Given this list of marker genes Arfgap3 (ADP-ribosylation factor GTPase activating protein 3), Mtif2, Rasgrf1, Rapgef6, Rab24, Thtpa, Trip13, Kif5a, Rapgef3, Drg1, Smc6, Ddx47, Atad2, Sergef, Trpm2, Arl4d, Nudt6, Atp2c2, Fgd5, Kras, Spata13, Mfn1, Gem, Ighmbp2, Abcc6, Arhgap15, Septin1, Evi5l, Atp8b5, Ascc3, Tbc1d9b, Nvl, Adap1, Dhx58, Fitm2, Efl1, Gbp6, Obscn, Vav1, Hspa1a, Atp8b1, Prex1, Mcm4, Dcp1b, Gbp10, Abca12, Arhgap9, Grtp1 (GH regulated TBC protein 1), Psd3, Itsn1, Arhgef28, Arhgap35, Rabl2, Anxa7, Kifc5b, Abca6, Rhob, Iqsec3, Kifc2, Rnd2, Irgm2, Entpd3, Plcb1, Abcg8, Abca8b, Eif5, Arl6, Arl5c, Myo5a, Rragd (Ras-related GTP binding D), Zng1, Sh3bp5l, Ccdc88c, Arhgap12, Rgs7, Smarca4, Tuba1b, Psmc2, Tbcd, Abcb1a, Atp7b, Llgl1, Dennd5b, Ak6, Rasgef1b, Cyth4, Dhx15, Frmd7, Cant1, Phospho1, Rad51b, Nudt14, Nucb1, Gnas, Ola1, Rab9, Eif2s3y, Dennd1b, Psd2 (NCBI Gene Id 74002), Rheb, Dna2, Mcf2, Rhobtb1, Atp5f1a, Tap1, Gnb2, Arhgap23, Atp5po, Tbc1d10a, Rit2, Abca9, Atad2b, Ddx10, Arhgap5, Fignl2, Rhoa, Rcc2, Dqx1, Arhgef25, Arfgef3, Rap1gap, Gtpbp4, Arhgap33, Arhgap19, Elmod1, Dcp2, Rasa1, Rab26 (NCBI Gene Id 328778), Gdi1, Dhx30, Dab2ip, Thy1, Ift22, Tbc1d25, Rab10, Rhof, Atp11a (ATPase, class VI, type 11A), Rab39b, Tdrd9, Atp6v1a, Dock5, Enpp1, Arl2bp, Eif2s3x, Ric1, Rgs20, Mx2, Mcm3, Tbc1d14, Yme1l1, Htr2b, Agap1, Sgsm3, Rasa2, Afg3l1, Rab3b, Als2, Dock8, Abcc10, Abcd4, Ifih1, Macf1, Tubb4b, Irgc, Cyth3, Dock10, Rhot2 (ras homolog family member T2), Abcb6, Lsg1, Msh2, Arhgap6, Nudt11, Atp2b2, Iqsec1, Ralgapa1, Ralbp1, Arap2, Swsap1, Atp2a2, Abcc12, Prex2 (NCBI Gene Id 98394), Ralgps1, Mov10l1, Rab27a, Rgs17 (NCBI Gene Id 80505), Septin4, Rap1gap2, Abr, Rgs6, Dennd10, Atrx, Rab7, Rras2, Supv3l1, Myo9b, Arhgap22, Nudt16l1, Fitm1, Plekhg6, Atp2a3, Dock4, Ino80, Cct7, Gbp3, Arhgef15, Sbf1, Rgs5, Rasl10b, Arl5b, Gm5431, Rab33a, Dnah3 (dynein, axonemal, heavy chain 3), Mfn2, Gopc, Rasgrp2 (RAS, guanyl releasing protein 2), Evi5, Dhx57, Katna1, Iigp1, Nav1, Flcn, Plekhg1, Akap13, Kif17, Ocrl, Rnd3, Arfgef1, Tbc1d21, Rap1a, Nudt16, Rad50, Kif1c, Arhgef10, Rhobtb3, Tubb2b, Eif2b1, Atp1a4, Rgs11, Dock1, Dnm1l, Tiam1, Kif15, Rem2, Gnal, Rab4a, Gapvd1, Nubp1, Rab36, Atl3, Mtg2, Ddx19a, Tubb1, Ddx46, Myo1e, Fancm, Chd8, Sipa1l3, Ranbp2, Kif2b, Plpp6, Abcb10, Dgki, Dennd2a, Sipa1l1, Nlrp3, Helq, Tbc1d20, Psmc3, Iqgap1, Chd1l, Dmc1, Abcg3, Ruvbl1, Srcap, Ran, Eif2b2, Dcp1a, Rasgef1c, Myo3a (NCBI Gene Id 71549), Entpd2, Xrcc6, Kif5c, Arhgap8, Nudt5, Elmo1, Gna12, Rgl1, Kif7, Gm12185, Rab1a, Srp54c, Sh3bp5, Myo9a, Rhoj, Lonp1, Chn2, Atp13a5, Abcd3, Entpd7, Gng2, Arhgap29, Chd6, Tbc1d5, Rab7b, Dennd6b, Rgs1, Arhgap24, Diras1, Dnmbp, Sipa1l2, Cftr, Chtf18, D1Pas1, Ankrd27, Gnl1, Septin12, Ddx27, Arhgef10l, Ddx51, Blm, Rfc2, Rfc3, Eif4a1, Abcc2, Rasal3, Nudt17, Ralgds, Arf6, Ddx11, Arhgap20, Kif13b, Ythdc2, Abcd2, Fam13b, Kif1b, Fgd1, Atp5pb, Rab43, Psmc6, Psmc1, Adprm, Arf1, Rasgrf2, Acap1, Rin1, Abcc4, Ddx17, Atp6v1g3, Dennd2d, Morc2a, Tppp, Katnal1, Arhgap42, Mtss2, Gdpgp1, Gnao1, Gbp4, Gna11, Rab3gap1, Adap2, Tor4a, Kif2c, Mcm8, Plcd4, Kif13a, Rgs12, Spg7, Ralgapa2, Gm4841, Gnaq, Pms2, Arhgdia, Nudt9, Vav2, Igtp, Trap1, Fignl1 (NCBI Gene Id 60530), Plekhg5, Abce1, Rasef, Sh2d3c, Atp10d, Snrnp200 (NCBI Gene Id 9996), Rab38, Hspa8, Slfn8, Gripap1, Pelo, Gm1527, Als2cl, Tagap, Arf4, Ntpcr (nucleoside-triphosphatase, cancer-related), Arhgap25, Arl8a, Abca4, Rasgef1a, Afg3l2, Dock11, Aqr, Rab2a, Srgap2, Rapgef5, Arhgef1 (Rho guanine nucleotide exchange factor 1), Nuggc, Plce1, Hspa1l, Hltf, Kif12, Pgam5, Fhit (fragile histidine triad gene), Rfc1, Rab11a, Recql4, Iigp1c, Chm, Upf1, Gnat3 (G protein subunit alpha transducin 3), Arhgap31, Agap2, Abca1, Smc4, Rhot1, Rpgr, Septin10, Abcc3, Sgsm1, Eif5b, Srgap3, Rhov, Tsr1, Dennd2b, Agap3, Gnb1, Tcp1, Kif21b, Rerg, Ppa1, Abca13 (NCBI Gene Id 435246), Dnajc27, Ralgapb, Abcg1, Septin8, Kif2a, Vps4b, Eps8l1, Drg2, Sesn2, Nudt12, Rasa4, Arhgef7, Arhgef39, Rab32, Dennd4b, Eif4a3, Abcg4, Tubb2a, Gdi2, Rab17, Ddx49, Stard8, Arhgef18, Rabif, Dhx8 (DEAH-box helicase 8), Cracr2a, Hsp90b1, Cdc42ep2, Mcm6, Atp1a1, Psmc4, Hsp90aa1, Helz2, Ddx50, Myh3, Ddx28, Rhebl1, Entpd4, Atp2c1, Kif18a, Gnai2, Eftud2, Arhgef2, Sbf2, Gbp2b, Rin3, Arhgdib, Gpsm3, Kif14, Tsc2, Slit2, Rtel1, Abcf3, Ddx3y, Abcf1, Rasgrp4, Gch1, Rab22a, Rigi, Myh8, Gnat1, Tor1a, Lamtor2, Fgd6, Vps4a, Plpp5, Ddx1, Slc25a42, Kif21a, Morc3, Arfgef2, Fgd3, Dennd3, Tbc1d4, Chd5, Get3, Ddx20, Rab13, Tbc1d10b, Hspa1b, Wrnip1, Eps8l3, Abca5, Gmip, Arhgef38, Nudt18, Elmod2, Entpd6, Ngb, Prune1, Cct6a, Kif16b, Rasa3, Jun, Gtpbp2, Rap1gds1, Nkiras2, Kif26a, Nlrp1a, Dhx34, Stard13, Rabgap1l, Abcb11, Arhgap18, Ranbp10, Dnah2 (dynein, axonemal, heavy chain 2), Arhgap26, Rad51, Tubb3 (tubulin, beta 3 class III), Arf2, Gnai3, Rab30, Rcc1l, Rab8b, Gfm2, Pex6, Rab42, Abcb9, Gna15, Atp10b, Madd, Rad51d, Arhgef16, Tbc1d1, Arhgef6, Hfm1, Rp2, Sec61b (SEC61 translocon subunit beta), Mcm5, Kif3b, Tbc1d22a, Smchd1, Atp13a2, Nudt2, Arhgap21, Ercc6, Ccdc88a, Arl14, Gng4, Srp54a, Trim23, Gna13, Arhgap40, Nrp1, Rhog, Rinl, Nlrp1b, Aptx, Gbp2, Septin11, Tor3a, Actb, Arhgef17, Atp5f1c, Atp8b3, Psd4, Rgl2, Rab39, Smc1b, Tbcc, Chd9, Mlh1, Ric8a, Atad3a, Asap1, Acap3 (ArfGAP with coiled-coil, ankyrin repeat and PH domains 3), Ddx56, Morc4, Hspa5, Entpd1, Sec23a (NCBI Gene Id 217612), Rab6b, Rgs10, Cpeb2, Rab33b, Psmc5, Syde1, Entpd4b, Arhgap32 (Rho GTPase activating protein 32), Rabgef1 (RAB guanine nucleotide exchange factor (GEF) 1), Rgs14, Cdc6 (cell division cycle 6), G3bp1, Gpsm1, Ophn1, Bms1, Tiam2, Smpdl3a, Rap2a, Wdr41, Ercc2, Gbp7, Rasl12, Kif27, Cyth1, Gpsm2, Arhgap1, Pex1, Tbc1d15, Alpl, Deptor, Arhgef4, Rab9b, Rhoq, Kif3c, Arl11, Syde2, Ddx4, Nudt15, Sar1a (NCBI Gene Id 67913), Rhobtb2, Wrn, Cplane2, Abcb7, Iqgap2, Rapgefl1, Ifi47, Cct8, Arhgef12, Arhgap17, Twnk, Dock9, Rac3 (Rac family small GTPase 3), Tor1b, Lamtor1, Atp13a4, Rab3ip (RAB3A interacting protein), Atf7ip (NCBI Gene Id 76012), Hsp90ab1, Smarcad1, Srgap1, Abcg5, Mcm2, Abcd1, Chd4, Ddx3x, F830016B08Rik (RIKEN cDNA F830016B08 gene), Iqca1, Dennd5a, Arhgap27, Rit1, Arl15, Slfn9, Nudt3, Entpd8, Rab3a, Rngtt, Arhgef33 (Rho guanine nucleotide exchange factor 33), Sirpa, Ect2, Mycbp2, Kifc1, Rab18, Gnb4, Chd3, Xrcc5, Arhgap28, Arl4c, Gng3, Gtpbp1, Ift27, Atp4a, Ccz1, Rapgef4 (NCBI Gene Id 71744), Dhx32, Abca7, Smc3, Rab3d, Hmgcr (NCBI Gene Id 218474), Abcc9, Rab4b, Dnah5, Rgs16, Asap2, Tgtp1, Atp2a1, Tns3, Kif5b, Pif1, Myo5b, Nudt19, Rabep1, Ddx52, Gpn1, Dnm3, Rap2b, Llgl2 (NCBI Gene Id 71593), Chd7, Net1, Smc2, Myo19, Arrb1, Entpd5, Eif4a2, Rnd1, Sos1, Dnah8, Chd2, Ddx59, Tbc1d2b, Atp9b, Ddx41, Arl1, Ddx18, Recql, Atp5f1b, Nf1, Arhgdig, Cavin4 (NCBI Gene Id 68016), Abcg2, Guf1, Mmut, Arl4a, Dhx33, Grb2, Nprl3, Acyp1, Arhgap44, Dennd4a, Rasgrp3, Git1, Nudt1, Ralgps2, Tbc1d22b, Gm12250, Rab40b, Mtrex, Dennd11, Iqgap3, Gipc1, Itpa, 1700006A11Rik, Septin5, Nav3, Atad5, Eef1a2, Arhgap4, Abcf2, Agfg2, Dlc1, Usp6nl, Nsf (N-ethylmaleimide sensitive fusion protein), Dcps, Brip1, Cct6b, Arhgap39, Mcm7, Nudt10, Elmod3, Rasd1, Dock7, Sh3bp4, Cct5, Rapgef2, Eef1d (eukaryotic translation elongation factor 1 delta), Kalrn, Tbc1d8b, Rhou, Fgd2, Chn1, Rab35, Helb, Ddx21, Gnb5, Atp10a, Gspt2, Abca3 (NCBI Gene Id 69158), Rab11b, Septin3, Gpn3, C9orf72, Vps9d1, Ppa2, Rad17, Nras, Vwa8, Gnb3 (NCBI Gene Id 14695), Enpp3, Mov10, Nckap1l, Rab6a, Nudt13, Sh3bp1, Krit1, Cyth2, Katnal2, Mcm9, Gpn2, Spast, Rab3c, Git2, Arf5, Atp8a1, Tubb4a, Ddx39a, Hspa13, Rgs8, Hps4, Sec23b, Ranbp1, Gnaz, Tbc1d12, Rab28, Sipa1, Rab44, Tbc1d30, Dhx29, Morc2b, Rabl3, Rraga (Ras-related GTP binding A), Rnf213, Arl2, Dennd1a, Ddx55 (NCBI Gene Id 67848), Arl3, Rab8a, Rab5c, Rangrf, Tap2, Mlh3, Gbp9, Orc4, Rras, Atp8b2, Rab1b, Rapgef1, Kif23, Arf3, Rem1, Iqca1l, Farp1, Kif3a, Irgm1, Nlrp10, Kif19b, Abcb8, Arfrp1, Rac2, Hps1, Dock3, Diras2, Chrm4, Atp6v1g1, Rab23, Cdc42, 4930544G11Rik, Clu, Rab37, Dennd4c, Lamtor3, Preb, Dhx40 (DEAH-box helicase 40), Rab3gap2, Farp2, Dnm2, Atp5pf, Pgp, 9930111J21Rik1, Rfc4, Egf, Gna14, Arhgap36, Gfm1, Atp5f1e, Rad54l, Enpp2, Ddx54, Pcp2, Kif28, Fbxo8, Ddx24, Chd1, Tbc1d13, Tbck, Rtkn, Nucb2, Gm266, Ddx42, Lamtor5, Carns1, Mras (muscle and microspikes RAS), Rnf112, Arap3, Atp13a3, Tubb5, Rala, Racgap1, Recql5, Abca17, Dhx36, Rasd2 (NCBI Gene Id 75141), Rab34, Arhgef37, Afg1l, Lhpp (NCBI Gene Id 76429), 1700009N14Rik, Clpx, Ide, Pfn2, Bcs1l, Dync1h1, Rab2b, Rasgrp1, Sos2, Rab19, Rab15, Plpp1, Rabep2, Atp1a3, Rab20, Rab14, Trio, Atp2b1, Rasl11b, Myh7, Acap2, Wnt11, Thg1l, Rhoh, Slc38a9, Tbc1d7, Tbc1d16 (NCBI Gene Id 328045), Rasl2-9, Tubb6, Nudt8, Smap2, Tbc1d10c, Abca2, Rasl11a, Opa1, Rab3il1, Gngt1 (NCBI Gene Id 14699), Clpb, Prune2 (NCBI Gene Id 77754), Psd, Kif22, Smap1, Dnaja3, Rgs4, Rgl3, Tbc1d9, Itsn2, Eps8l2, Rap2c, Nudt7, Eef2, Hras, Bcr, Pde6d, Rab21, Rabgap1, Ralb, Rab25, Ercc3, Depdc5, Rhod, Arhgef3, Dennd1c, Stxbp5, Srpra, Kif9, 2310057M21Rik, Rgp1, Rab5b, Tbc1d24, Gars1, Arhgap45, Orc1, Ddx39b (DEAD box helicase 39b), Lrrk2, Arfgap2, Polq, Arhgef40, Rgs3, Arhgef11, Ngef, Atp11b, Lonp2, Rhoc, Arhgef9, Eif2b5, Fgd4, Rragc, Dut, Gtpbp3, Ddx5, Cct2, Abca8a, Kif20a, Arhgap10, Shoc1, Rap1b, Atp12a, Dxo, Irgq, Rangap1, Eif2b4, Abcc1, Abcb1b, Septin6, Arl13a, Atp9a, Atad1, Acyp2, Adgrb3, Mmaa, Smcr8, Rragb, Nudt22, Plcg1, Tbc1d17, Tgtp2, Itgb1bp1, Rrad, Sar1b, Arl8b, Fign, Eef1b2, Rgs9, Plpp4, Mtg1, Atp1a2, Abcb4, Eefsec, Ddx6, Gnat2, Iqsec2, Srp54b, Sgsm2, Dock6, Dync2h1, Ric8b, Rgs2, Rin2, Lamtor4, Atp2b4, Gbp8, Eif2b3, Ddx25, Dctpp1, Adss1, Atp6v1g2, Rfc5, Atp8a2, Gspt1, Enpp4, Prr5, Hspa9, Syngap1, Tufm, Vav3, Kif19a, Mcf2l, Smc1a, Abcb5, Depdc1b, Atp11c, Depdc1a, Dhx9, Tdrd12, Smarca5, Nudt4, Dock2, Kif18b, Abcc5, Afg2b, Ruvbl2, Nkiras1, Mx1, Arfgap1, Chml, Septin7, Atp5f1d, Nprl2, Septin14 (septin 14), Rab5a, Kif1a, Kif20b, Asap3, Gnai1, Atl2 (atlastin GTPase 2), Plekhg2, Atl1, Dnm1, Arhgef19, Arhgap30, Enpp5, Garnl3, Arl13b, Rgs18, Rcc1, Gbf1, Atp13a1, Fbh1, Gtpbp10, Rasl10a, Dennd2c, Afg2a, Septin2, Pms1, Vcp, Kif6, Rab27b, Arl5a, Rab29, Stxbp5l, Arap1, Septin9, Arhgef5, Arhgap11a, Dis3, Cct4, Eras, Cct3, Hspa14, Arl10, Dennd6a, Gbp5, Ercc6l, Tor2a, Plekhg3, Tbc1d8, Agfg1, Kndc1, Rab40c, Rab12, Ddx31, Rac1, Hbs1l, Rab31, Bcar3, Atp7a, Mon1a, Dnah12, Rad54l2, Hspa2, Dolpp1, Eef1a1, Tbc1d2 (NCBI Gene Id 381605), Gngt2, Rasal1, Gimap7, Lars1, here is a description of the gene set: studied in species Mus musculus Catalysis of the hydrolysis of any acid anhydride. Mouse Gene Set: GOMF_HYDROLASE_ACTIVITY_ACTING_ON_ACID_ANHYDRIDES